The following is a description of a gene set: from publication Ochiai K, Maienschein-Cline M, Simonetti G, Chen J, Rosenthal R, Brink R, Chong AS, Klein U, Dinner AR, Singh H, Sciammas R (PMID 23684984) Human Gene Set: GSE46606_UNSTIM_VS_CD40L_IL2_IL5_3DAY_STIMULATED_IRF4MID_SORTED_BCELL_DN Genes down-regulated in at day 0 B cell IRF4-KO versus CD40L and IL-2 IL-4 IL-5 stimulated at day 3 B cell IRF4intermediate. Temporal analysis of B cell activation in vitro using CD40L and IL-2/4/5 cytokines in wild type Irf4+/+ B cells or in mutant Irf4-/- B cells harboring a tet-inducible allele of Irf4. IRF4 expression was restored, or not, in the Irf4-/- background by culturing in the presence of low or high concentrations of doxycycline. The results provide insight in the role of IRF4 expression levels in coordinating different programs of B cell differentiation. species: Homo sapiens, and this is the list of marker genes: CEMIP2, PRRT1, MAX, NR4A3, RNF168, INTS8, CDKN1A, MIR124-1HG, THEMIS2, AZIN1, JUND, CD70, MXD1, GBP2, IL15RA, PLAGL1, ATP6V1D, PTTG1, TIFA, ING1, NRROS, TRIM34, AZI2, MINDY3, MREG (NCBI Gene Id 55686), DDX1, KHDRBS3, PLK3, NFKB2, NUDT9, SOCS6, AMN1, RIPK2, C19orf12, GPR18, SHISA5, CCL5 (C-C motif chemokine ligand 5), PPFIA3, OAS1, PPP1R11, PTGS2, LAD1, AGRN, DNAJC7, BLOC1S4, MFHAS1, POLR2C (RNA polymerase II subunit C), NEU1, RHOB, ATP10A, ISG15, FNDC3A, EHD3, JUN, TRA2A, MYO5A, RBL1, ARAP2, STAP1, BBX, PLXND1, CISH, NFKBIL1, BHLHE40, SMARCE1, STAT2, CASP4, TLCD1, SOCS3, IFITM3, BRWD3, NF1, EHD1, RHOH, ILDR1, BCL2L1, ZNFX1, UNC5B, TIPARP, MACIR, PIGV, LENG9, HS2ST1, TOX4, GTF2A1, TREML2, DYRK2, GEM, CTTNBP2NL, ATXN1, GABPB1, CEACAM21, TMEM168, DRD4, AXL, TGFB3, SH3BP4, REL, NRP1, ARF4, PBX4, OR2T33, GHITM, GTF2E2, UBXN7, CPNE3, EEF1E1, SYNPO2L, ADM, ARID5A, HAPLN2, ZFYVE26 (zinc finger FYVE-type containing 26), RNF213, ATP1B3, TMEM248, MTMR11, MTHFS (methenyltetrahydrofolate synthetase), WDR59, RFX5, PPP1R10, EBI3, ALCAM (NCBI Gene Id 214), RASGEF1B, FMNL2, EIF4ENIF1, ZHX2, CCL1, TNFSF9, MYO1G, SLC3A2, MLKL, CASP3, AEBP2, DENND5A, TNNI1, PPA1, AFTPH, SNX11, ARHGEF3, TPST1, UBALD2, C3orf38, SMIM3, GZMB, TNIP1, BVES, TRAF5, CORT, FBXW11, GRB2, PPP2R2A, HYCC1, ZBP1, PECAM1, TOR1AIP2, OTULIN, B3GNT2, TRAFD1, JAK2, BATF, SLC2A6, ATP6V1C1, ALDH1B1, KNL1, TMEM39A, STRIP2, IL2RA, CDK5R1, XIAP, MAP3K5, NFKBIB, RTP4, FGL2, NDST4, HCAR2, HNRNPC, OCIAD1, SETDB2, IGSF8, KPNA3, SAMD9L, GBP6, SIPA1L1, IFIT1B, USP15, MGAT5 (alpha-1,6-mannosylglycoprotein 6-beta-N-acetylglucosaminyltransferase), PSMD11, PLA1A, KRTAP19-3, OPTN, NFKBIA, PRRG4, ZC3H12A, CASP8, TMOD3, SWAP70, CMYA5, FBXO11, BASP1 (NCBI Gene Id 10409), TANC2